Given this list of marker genes HEXB, RAPSN, PRNP, SCN4A, NAGS, PDHA1, PRR12, AGRN, ZNHIT3, THRA, SLC25A13, NKX2-1, DNMT1, COL13A1, CHRNB1, FBP1, AIP, NKX2-5, KCNJ11, CHRNA1, MTRR, MUSK, HCRT, ASL, NDUFS8, TDP2, DOK7, HNF4A (hepatocyte nuclear factor 4 alpha), HMGCL, TRANK1, AK9, ABCC8, ATP1A2 (NCBI Gene Id 93186), CACNA1A, CHRND, PTS, DUOX2, HNF1A, MT-CYB, SLC19A3, OTC, LRP4, PTRHD1, UCP2, SLC13A3, PAX8, SLC26A4, PIGG, UBAP2L, MOG, MAN2B1, GPR101, SPR, LONP1, FOXE1 (NCBI Gene Id 7081), CHRNE, TSHR, GFAP, here is a description of the gene set: Drowsiness Human Gene Set: HP_DROWSINESS species: Homo sapiens Abnormal feeling of sleepiness or difficulty staying awake.